Given this list of marker genes TDP1, REPS1, GCLC, ATXN2, GJB1, PLP1 (proteolipid protein 1), ATXN3, MAN2B1, ATXN1, RRM2B (NCBI Gene Id 50484), RNASEH1, PRKAR1B, here is a description of the gene set: Abnormality of the spinocerebellar tracts species: Homo sapiens Human Gene Set: HP_ABNORMALITY_OF_THE_SPINOCEREBELLAR_TRACTS An abnormality of the spinocerebellar tracts, a set of axonal fibers originating in the spinal cord and terminating in the ipsilateral cerebellum. The spinocerebellar tract convey information to the cerebellum about limb and joint position (proprioception). They comprise the ventral spinocerebellar tract, the anterior spinocerebellar tract, and the posterior spinocerebellar tract.